Given this list of marker genes Map3k13, Stk25, Map2k6, Mid1, Mapk8ip2, Il1b, Inava, Qars1, Clec7a, Kat7, Crhr2, Foxo1, Mapk8, Mapk1, Nod2, Mapk13, Errfi1, Cryab, Taok3, Taok1, Tgfb2, Eif2ak2, Rhoa, Arl6ip5, Ripk2, Prdx1, Map2k3, Map2k1, Scimp (SLP adaptor and CSK interacting membrane protein), Dusp10, Agt, Mapk3, Nbr1, Zmpste24, Gfral, Map3k7, Cd2ap, Fas, Akr1b1, Card9, Hmgcr (3-hydroxy-3-methylglutaryl-Coenzyme A reductase), Ppia, Usp25, Sema4c, Mapk14, Map2k2, Pbk, Klhdc10, Grem1, Mapk11, Map3k20, Map2k7, Taok2, Tlr4, Pdcd10, Nod1, Map3k5, Igfbp6, Gstp1, Il1a, Foxm1, here is a description of the gene set: Mouse Gene Set: GOBP_STRESS_ACTIVATED_PROTEIN_KINASE_SIGNALING_CASCADE studied in species Mus musculus The series of molecular signals in which a stress-activated protein kinase (SAPK) cascade relays a signal.